Given this list of marker genes F8, F10, F9, here is a description of the gene set: studied in species Homo sapiens Factor VIII (FVIII) in its activated form, FVIIIa, acts as a cofactor to the serine protease FIXa, in the conversion of the zymogen FX to the active enzyme (FXa). Missense mutations within the S577-Q584 region of FVIII have been associated with mild/moderate hemophilia A (HA) (Amano K et al. 1998; Celie PH et al. 1999; Jenkins PV et al. 2002). A functional assay demonstrated that the mutations S577F, V578A, D579A, and Q584R interfere with FVIIIa:FIXa-mediated stimulation of FX activation thus the effect of the mutations is to reduce the cofactor potential of FVIII in FXa generation. part of: Defective factor VIII causes hemophilia A Reactome Pathway: Defective cofactor function of FVIIIa variant